The following is a description of a gene set: Catalysis of the reaction: acyl-CoA + 2-acylglycerol = CoA + diacylglycerol. Human Gene Set: GOMF_2_ACYLGLYCEROL_O_ACYLTRANSFERASE_ACTIVITY studied in species Homo sapiens, and this is the list of marker genes: MOGAT1, MOGAT2, AWAT2, LPGAT1, DGAT1, MOGAT3, DGAT2